The following is a description of a gene set: Human Gene Set: MIR548AO_3P from publication Chen Y, Wang X (PMID 31504780) studied in species Homo sapiens Genes predicted to be targets of miRBase v22 microRNA hsa-miR-548ao-3p in miRDB v6.0 with MirTarget v4 prediction scores > 80 (high confidence targets)., and this is the list of marker genes: MYCBP, EYA4, MFSD14A, OXR1, ELK4, KCNN3, MAFA, DYRK1A, ZNF521, XPR1, SH3GLB1, PTCHD1, ACACA, YBX1, CSRNP1, DNAL4, HOXD10, CLEC12B, XRCC5, SIGLEC14